Given this list of marker genes MAP2K5, VEGFA, TMEM80, SPACA9, SAMD4B, TRIM8, SNHG14, NINJ2-AS1, GNB5, FIG4, GSTM1, TRAPPC6B, ERN1, FCER1G (Fc epsilon receptor Ig), GPAT3, PA2G4P2, NPM3, ERICH1, PDCD2L, NFIL3, SMARCD1, NDE1, ZNF789, HCST, CARHSP1, NUMB, RNF7, NRP1, PTPRE, MYO1B, ALDH6A1, SLFN13, ARRDC3, FAM204A, LLGL2, IFIT3, LINC00205, TRIOBP, NNT-AS1 (NCBI Gene Id 100653173), ZCCHC24, PLEKHH1, ASNS, ZNF436 (zinc finger protein 436), AARS1, OSBPL7, MPO, DDX21, SKA1, ATP6V1E2, DDX46, PCK2, CCDC92, CCDC88C, TRAFD1, GATAD1, URB1, PTBP3, HSPA13, TM7SF3, EPOR, RIOK1, SCYL2, SPPL2A, HLA-F, PTER, MAP3K5-AS2, KLHL24, RBM39, MCEMP1, CD320, NAMPT, CD55, B3GLCT, MSRB2, DEPTOR, NPHP3, CBX5, SLC38A2, PRKCA, CAPN2, FAM118A, ITM2B (NCBI Gene Id 9445), KLF4, KIF9, PMAIP1, CLN6, KDM7A, ETV5, NUTM2A-AS1, FAM3A, PCBP1-AS1, SLC12A6, MTHFD2L (methylenetetrahydrofolate dehydrogenase (NADP+ dependent) 2 like), MR1, TRMT13, GTF2H1, PXN-AS1, TMEM65, ING4, SEL1L3, BOP1, UMPS, SMCR8, SLC3A2, EIF3B, CACNA2D4, NEK1, CCDC50, HDAC9, KCNE3, GTPBP2, RCN1, ZNF33B, FTH1P5, METTL4, GPR137B, ZSWIM6, SEPSECS, BGLAP, CD48, SEPTIN7P13, CYBB, GPT2, TRIQK, KHSRP, ZCCHC8, SYNE3, JMJD8, SCYL3, HAGH, ZBTB46, GPCPD1, SCAF4, ZNF224, DNAJB9, PLCH1, NASP, MZF1, DDIT4, FSBP, GFPT1, NFE2L1, STK3, GAS6-AS1, CARS1, ZNF133, CEP19, TAFAZZIN, BLVRB, RARA, GPR84, ACY1, CRTC2, KTI12, PTPRC, TFEC, CHMP1B, RNF146, SFXN4 (sideroflexin 4), USP9X, FSD1L, ATL2, GNL1, PIERCE2, ZBTB6, FARSA, ADRB1, GADD45A, ESYT2, ZNF18, TMEM268, SCAF11, SH3YL1, TRIB2, SH3BP2, ABHD2, ANKRA2, ST3GAL1, RNF2, LINC-PINT, ZNF536, AGPS, ZSCAN16, PIK3CA, NOC3L, KRBOX4, ST7L (NCBI Gene Id 54879), ARK2N, CTH, VLDLR, PRMT1, USP7, EXOSC5, ARHGAP30, RPL22L1, SLC36A4, RPP40, SLC2A3, NPIPA1, KIZ, ATOSA, AAK1, KRCC1, ST20, ARL4A, ZNF566, SSH1, AK6, ANXA3, METTL8, NHLRC3, F11R, PLEKHA5, ARID4A, TCEA3, FBXL13, TPM4, SH3GLB1, TBC1D4, ARFGAP3, FYN, GFOD1, NR1H3, UGGT2, INPP5K, ENAH, POLR1F, SLC37A4, ACAA2, TCF12, BMS1P1, DPH2, LSS, IKZF5 (NCBI Gene Id 64376), ZNF569, RPL5, ARL17A, ZEB2, IGF2R, RIOK3, NAA15, GKAP1, HLA-A, ERAP1, SESN2, CTTN, RBCK1, NMRK1, ORM1, BCL6, SGTB, OGFRL1, LINC00662, YJU2B, CCDC71L, LGALS1, RGS2, HCK (HCK proto-oncogene, Src family tyrosine kinase), PRG2, ZMYM5, HACD2, MTMR6, JAG1, RPAIN, THUMPD3-AS1, IL1RN, SLC1A4, KDM6A, RFC5, PCNX1, ADGRE2, TCF4, EME2, PKD2, RGS16, LACC1, ENTPD4, MLST8, CDK6, PTP4A3, S100A9, ITPR1, CLPB, CHD6, PFDN6, RNF185, SEC22C (SEC22 homolog C, vesicle trafficking protein), ACSL1, PRKACB, ZER1, WDFY1, NICOL1 (NELL2 interacting cell ontogeny regulator 1), VSIR, GAL (galanin and GMAP prepropeptide), TIMM9, HLA-E, ZNRD2, INAFM1, DDX31, KLHL5, POC5, JAK1, NBR1, RAB2B, DAPP1 (dual adaptor of phosphotyrosine and 3-phosphoinositides 1), TOMM40, CDKN1A, SCO1, ARMC8, LINC00926, AJUBA, ALOX5, DAZAP1, RAP2A, SEMA4A, MLLT11, SHMT2, ARAP2, SEC24D (SEC24 homolog D, COPII coat complex component), CCPG1, C1QBP, SLC7A1, CD40, SUCNR1, TNFRSF10B, MAFB, RALGAPA1, AGO4, CDK19, MORF4L2, ITGAV, DDX59, TMED3, LIPT2-AS1, BCL11A, GBP3, FUT4, CKMT2-AS1, GMDS, YPEL5, BBS7, RET, PPP1R15A, GGPS1, USP19, BST1, XIAP, CCNB1IP1, DNAJC12, ZNF174, SH3PXD2A, NKIRAS2, RNF126, WDR43, HOXD13, CCL2, SNHG33, CARD19, AKAP13, CHKB, S100P, KAT2B, NBDY, ZNF274, TTYH3, RAB4B, FMNL2, USO1, PPIP5K1, GFM1, DDB2, IDH1, IL18, AURKAIP1, SECISBP2L, KLF9, PLEKHA1, WARS1, RCL1, G6PD, PITX1-AS1, STIM1, FRA10AC1, FOXJ2, TGIF1, ZMYM2, STK39, CDK17, BCL3, NABP1, ADGRA3, ITPRIP, LYZ, SMOX, SUPV3L1, PLAGL2, IFRD1, ATAD2B, S100A8, SLC38A5, ARHGEF9, SLC29A1, CYLD, PHGDH, AZI2, CTSS, NDUFAB1, CXCL8, FAM174C, ETS1, PDCD11, NPIPB3, LETMD1, BSDC1, OGT, GOLGB1, GSPT1, AP1S2 (NCBI Gene Id 8905), RSRP1, MS4A3, SLC39A14, PGD, TM2D1, FILIP1L, EFHC1, POFUT1, CLIC4 (NCBI Gene Id 25932), BNIP3L, MTHFD2, WDR33 (WD repeat domain 33, NCBI Gene Id 55339), PSIP1, HLA-J, CD69, SLC49A4, UGGT1, CASP8, UBE2E2, OSBPL11, MORC2-AS1 (MORC2 antisense RNA 1), TIRAP, NSD3, PMVK, NBPF9, RECK, ATF3, ZBTB41, C19orf44, MED17, PREX1, TAPT1, TANK, PDCD4, PTPDC1, RAB32, CSRNP2, EFCAB11, UBALD2, PSAT1, PLIN2, VPS8, B3GNT5, RPS6KA5, FTH1, IRAK4, RETREG1, DCAF5, TMT1A, ZNF311, TMEM52B, MIRLET7D (microRNA let-7d), PIH1D2, RIOX2, CYTH2, KSR1, GPSM3, TES, TCP11L1, NOP14, TRMT5, ZNF621, ALOX5AP, AHSA2P, TTBK2, CUL4B, CAST, ARHGAP9, ITM2A, NFAT5, ZNF641, GORAB, STX16, ILF3, MARS1, PNPLA8, VPS35L, ATOX1, BTG1, PGAM5, VAMP4, HMGN5, TAP1, ARMCX3, NORAD, ZNF691, WSB1, SLC25A36, ZC3H6, NDUFAF4, PLP2, NME1, FAM149B1, MIPEP, SRD5A1, CHD2, MIR223 (NCBI Gene Id 407008), INPP1 (inositol polyphosphate-1-phosphatase), TIMM50, SSBP2 (NCBI Gene Id 51492), CD59, ATR, AKTIP, TAF15, ESF1, RNASEH1-DT, TUG1, PHF11, TALAM1, RPS6KC1, NOP9, ZNF277, NOL10, DNAJC1, UTP20, NEDD4, HBP1, APOLD1, FAM131B-AS2, CBS, ATXN1, CNOT7, DUSP6, TSC22D3, ABCB10, ZNF81, VARS1, TUBA1A, RPL10L, TFE3, TRAF3IP2-AS1, LIN7A (lin-7 homolog A, crumbs cell polarity complex component), RAB11FIP1, CENPBD1P, WDR74, ALDH1L2, ABCC4 (ATP binding cassette subfamily C member 4 (PEL blood group)), IRF2BPL, USP37, RPL37, GCC1, YIPF6, SETD7, DUSP5, UTRN, PUM3 (pumilio RNA binding family member 3), HMCES, NCOA3 (NCBI Gene Id 8202), NAP1L1, STC2, RHOBTB3, RANGAP1, TRAP1, PSTPIP1, SNX16, ATP5F1D, NAGK, RAB8B, SEC24A, PDCD5, FLRT2, HOMER1, METTL26, ASPHD2, FZR1, GARS1, EIF5, CEBPB, RABEPK, MFSD6, HBEGF, USP3, INPPL1, PHACTR2, SCAPER, SPG11, CBX4, LIMK2, DYNLT3, HMGCL, CPEB2, TXNL4A, MDM4, CELSR1, ZNF211, NQO1, CHAC1, CLEC7A, RALGAPA1P1, SYTL1, TMEM135, SLC22A15, CHI3L1, GABPB1-IT1, N4BP1, SLC12A9, RAB3IP, GLIPR1, ATG2A, SPRY1, ISOC2, NLN, ME1, TRIM38, BLTP3B, PCMTD1, ZNF222, THOP1, TPR, RSPH3, TNFRSF10D, FPR2, MIR124-1HG, CTBS, CREBL2, NIBAN1, MAFF, ABCC5, TRIM39, STAT2, ORAI3, KIF21B, ARRDC4, ZSCAN29, RFX3, SH3RF3, ZNF397, BID, AKNA, KIF1B, PHF21A, PWP2, LNPEP, STK4, NIFK, SKIC8, GRPEL2 (GrpE like 2, mitochondrial), IL18RAP, WDR75, MXD1, CCL3, MTPAP, FBL, DBN1, TMEM170B, AGA, SPMIP4, OTUD5, CR1, PLEKHA8, HIPK2, RNF41, CBLB, CD37, TUBE1, ZNF438, DUSP10, ANKMY1, PRNP, DNAJC10, SP100, APTX, N4BP2L2 (NCBI Gene Id 88523), QTRT1, FAN1, PSPH, PIGL, NEU3, TNRC6B, ALMS1, SERPINB6, SAMD9L, RETN, SIPA1L2, TUBA3E, IFRD2, NXT1, IFT80, RIT1, LINC00667, BBLN, NR1D2, MIR17HG, LRPPRC, EIF1, GOLGA2, PALS2, MYO1G, ARHGAP11B (Rho GTPase activating protein 11B), E2F7, TAF4B, TXNIP, UBE2H, MAP1LC3B, SH2B3, MOSMO, GOLGA1, C18orf32, IGFBP7, PROSER2, RBM4, MYO19, PNO1, MFSD8, SERPINB1, WDR45, LPL, C10orf143, ZNF623, TPK1, PTK2B, MIA2, ARRB1, NOP56, PTGR1, BRAP, CCDC69, SCAMP1, EPB41L3, MINDY2, MRPS25, KLF10, PKD1, MGC16275 (NCBI Gene Id 85001), PPDPF, UBE2L6, TIMM10, NOL4L, MID1IP1, FCGR1A, UTP15, SLC30A7, SLC25A40, PLPP5, PA2G4, GAS7, RBFA, ENSG00000284634 (novel transcript), PTPN23, PTH2R, YIPF4, NBR2, WNK1, LRRFIP1, EIF3M, BYSL, TSR1, ZNF518A, SRD5A3, SNTB1, MBNL2, BCL2A1, POLR1HASP, HACE1, FAS, TMEM143, TYROBP, SEMA4C, ERRFI1, H1-10, GALNT2, NUDT13, GARRE1, HIP1, ZNF696, CSGALNACT2, SRGAP2, PRRC2C, UBE2Q2P1, PARVB, APH1B, GGACT, POLG, NOLC1, IFT57, BMP2K, ACAT1, MUTYH, CARNMT1, ITPR2, C1orf74, SLC39A3, PLSCR1, TSPAN31, SHISA2, WDR4, SORD, PPP2R3C, IVNS1ABP, NOC2L, METTL25B (methyltransferase like 25B), COLGALT2, SLC16A6, CLIP1, ZNF451, DCAF15, HECA, NCEH1, SLC25A37, SLC25A24, MIR503HG, TTC7B, TMEM154, PACRGL, RHBDD1, ISL2, ZRSR2, ACTR3B, PML, LMO4, C8orf33, FOSL2 (NCBI Gene Id 79579), MEF2A, PAG1, SMIM14, TRAPPC6A, MAP7, LMBRD2, HCG18, TATDN3, B4GALT4, KDM6B, CSTA, PKP4, SEH1L, MBD6, CDC42BPA, PRMT3, DENND1B, TRIB1, CEP97, ERGIC2, BAZ2B, DNAAF5, MYO5A, SYNJ1, NEAT1, LPP, AMACR, SCARB1, PRIMPOL, GPATCH2L, EGR1, GABARAPL1, AP1G2, GTF2H2C, GNS, NCLN, TOR4A, CPEB4, TAGAP, RUVBL2, RAD51D, HLA-G, SGCB, GTPBP4, MYL12A, PLEK, CYP2R1, ASS1, MT1F, MIER3, TMEM87B (transmembrane protein 87B), KLHL2, CCDC169, FTSJ1, ZNF252P, LRP10, WDFY3, IRAG2, TRIM4, PTGER4, RAB27A, GNE, LPIN2, EARS2, USP27X, ELANE, FLOT1, TRIB3, ATF5, OGG1, P2RX4, CSKMT, EXOSC6, HEBP2, SKIL, NOC4L, NUP160, CHROMR, RAPGEF2, CHFR, PCID2, SEC14L1, H1-2, VPS39, ZNF652, ERI3, HTT, ERGIC1, TBL1X, OGA, RCBTB2, SNHG32, EMSY, VPS45, GRB10, ZNF230, SLC7A11, DEFA1, TFAP2E, BATF3, MAPDA, EDEM1, MAML3, CCNG2, PDE4D, CEP120 (centrosomal protein 120), ZNF330, SHPK, PEX1, here is a description of the gene set: from publication Krige D, Needham LA, Bawden LJ, Flores N, Farmer H, Miles LE, Stone E, Callaghan J, Chandler S, Clark VL, Kirwin-Jones P, Legris V, Owen J, Patel T, Wood S, Box G, Laber D, Odedra R, Wright A, Wood LM, Eccles SA, Bone EA, Ayscough A, Drummond AH (PMID 18701491) species: Homo sapiens CHR-2797 is a novel metalloenzyme inhibitor that is converted into a pharmacologically active acid product (CHR-79888) inside cells. CHR-79888 is a potent inhibitor of a number of intracellular aminopeptidases, including leucine aminopeptidase. CHR-2797 exerts antiproliferative effects against a range of tumor cell lines in vitro and in vivo and shows selectivity for transformed over nontransformed cells. Its antiproliferative effects are at least 300 times more potent than the prototypical aminopeptidase inhibitor, bestatin. However, the mechanism by which inhibition of these enzymes leads to proliferative changes is not understood. Gene expression microarrays were used to profile changes in mRNA expression levels in the human promyelocytic leukemia cell line HL-60 treated with CHR-2797. This analysis showed that CHR-2797 treatment induced a transcriptional response indicative of amino acid depletion, the amino acid deprivation response, which involves up-regulation of amino acid synthetic genes, transporters, and tRNA synthetases. These changes were confirmed in other leukemic cell lines sensitive to the antiproliferative effects of CHR-2797. Furthermore, CHR-2797 treatment inhibited phosphorylation of mTOR substrates and reduced protein synthesis in HL-60 cells, both also indicative of amino acid depletion. Treatment with CHR-2797 led to an increase in the concentration of intracellular small peptides, the substrates of aminopeptidases. It is suggested that aminopeptidase inhibitors, such as CHR-2797 and bestatin, deplete sensitive tumor cells of amino acids by blocking protein recycling, and this generates an antiproliferative effect. CHR-2797 is orally bioavailable and currently undergoing phase II clinical investigation in the treatment of myeloid leukemia. Genes up-regulated in HL-60 cells (acute promyelocytic leukemia, APL) after treatment with the aminopeptidase inhibitor tosedostat (CHR-2797) for 6 h. Human Gene Set: KRIGE_RESPONSE_TO_TOSEDOSTAT_6HR_UP